The following is a description of a gene set: from publication Szanto A, Balint BL, Nagy ZS, Barta E, Dezso B, Pap A, Szeles L, Poliska S, Oros M, Evans RM, Barak Y, Schwabe J, Nagy L (PMID 21093321) studied in species Homo sapiens Human Gene Set: GSE25123_WT_VS_PPARG_KO_MACROPHAGE_ROSIGLITAZONE_STIM_UP Conditional macrophage-specific PPARg knockout mice were generated on C57Bl/6 background by breeding PPARg fl/- (one allele is floxed, the other is null) and lysozyme Cre transgenic mice. PPARg and IL-4 signaling was analyzed on bone marrow-derived macrophages. Bone marrow of 3 mice per group was isolated and differentiated to macrophages with M-CSF (20 ng/ml). 20 ng/ml IL-4 was used to induce alternative macrophage activation and 1 uM Rosiglitazone (RSG) was used to activate PPARg. From each mouse 4 samples were generated: 1. M-CSF, 2. M-CSF+RSG, 3. IL-4 and 4. IL-4+RSG. All compounds were added throughout the whole differentiation process, and fresh media was added every other day. Control cells were treated with vehicle (DMSO:ethanol). After 10 days, RNA was isolated and gene expression profiles were analyzed using Mouse Genome 430 2.0 microarrays from Affymetrix. Genes up-regulated in bone marrow-derived macrophages treated with rosiglitazone: wildtype versus PPARG., and this is the list of marker genes: PHKB, FCHSD2, CHID1, TSPYL5, ZKSCAN4, ABCD4, CASP10, GLCE, PLEKHG5, B3GNT2, LPAR6, C1QA, SLC18B1, FOXK1 (NCBI Gene Id 650798), FAM118B, GOLGA4, DIRAS3, ZNF585B, SGMS1, MAL2, ZDHHC14, C1QB, CSGALNACT1, HS6ST1, ABCG2, CAPRIN2, ERCC3, AKR1A1, TMEM9B, ARHGAP35, GAS6, TMEM263 (transmembrane protein 263), POMGNT1, OLFML3, LRRC4, C1QC, CPQ (NCBI Gene Id 51670), FBXO34, VGLL4, NCKAP5, ZBTB4, IGF1, CNEP1R1, HOXB7, KCNQ1, MLXIP, NRIP1, CD163L1, OLFML2B, DAAM1, AIDA, SPATS2L, CARD6, VSIG4, MAP3K5, MVB12A, DNAJC13, WDFY3, ICA1, ITM2B, TNFRSF25, RHOBTB3, GGTA1, ITM2C, DIAPH2, ARID3A, RYR1, MTUS1, PDGFB, GPR34, VPS13D, H2BC8, SLC22A23, TP53INP1, CLTC, LGI2, HPGDS, DENND5B, ARHGEF12, MAMDC2, FEZ2 (NCBI Gene Id 9637), ANKS1A, TCEAL3, SMG8, PCDH12, SEC14L1, WNT5B, CYBRD1 (NCBI Gene Id 79901), NMRK1, PIK3R3, IQCE (NCBI Gene Id 54774), RASGRF1, FOLR2, CXCL12, BRAT1, CTSF, TBC1D12, HACD3 (NCBI Gene Id 95112), SLC25A4, ESR1, SKIDA1, BMPR1A, FAM110B (family with sequence similarity 110 member B), DDR1, SPIN1, GALNT4, ANKFY1, CARD11, UBA7, NDST2, LRP3, RUBCN, NFIA, CNRIP1, SIDT1, TMEM245, ARHGAP12, DST, GPR82, IKBKB, ARHGAP21, MANEA, GYPC, MGST2, SLCO2B1, EPHX1, CCND1, EPB41L2, SESN1, STON2, IKZF2, SCAMP5, ADAP2, SNX6, GAL3ST4, GATD3 (NCBI Gene Id 8210), HECTD2, ARHGAP5 (NCBI Gene Id 394), SLC1A3, DAB2, PWP2, ABHD14A, ATMIN, CITED2 (Cbp/p300 interacting transactivator with Glu/Asp rich carboxy-terminal domain 2), NRP1, RHPN2, MTSS1, RNF145, ST6GAL1, PALS1, FCGRT, SLC35E2B, TECR, SCN1B, BMPR2, TRIM50, H2AC8 (NCBI Gene Id 3012), DMD, WWP1, MAGEH1, TBC1D14, USP33, MAF, ETS1, SELPLG, EYA2, GPR155, NBL1, LTC4S, RUNX1, CRYBB1, WLS, EML1, TBC1D4, DISP1, TTC28, ADRB2 (adrenoceptor beta 2), NCK2, LPAR5, UBE2H, SNX13, SPTLC3, RAPGEF6, PPM1K, KIFAP3, CD14, USP51, STYXL2, MAP7, A2M, RPP25, HRH1, PLEKHA1, PHYKPL, BTBD7, DIP2B, RBM4B, BAG5, PDE9A, TSPAN31